Given this list of marker genes Ptdss1, Abhd12, Serinc2 (serine incorporator 2), Pla2g10, Serinc5, Pla2g3, Slc27a1, Lipc, Abhd16b, Mboat2, Abhd16a, Plscr1, Serinc1 (NCBI Gene Id 80452), Pla2g2f, Ptdss2 (phosphatidylserine synthase 2), Pla2g15, Lpcat3, Mfsd2a, Mboat1, Abhd12b, Lpcat4, here is a description of the gene set: The chemical reactions and pathways involving phosphatidylserines, any of a class of glycerophospholipids in which the phosphatidyl group is esterified to the hydroxyl group of L-serine. They are important constituents of cell membranes. Mouse Gene Set: GOBP_PHOSPHATIDYLSERINE_METABOLIC_PROCESS studied in species Mus musculus